Given this list of marker genes Mpi, Gck, Hk1, Man2c1, Man1c1, Gmppb, Man2b1, Pmm1, Pmm2, Man2a1, Man2a2 (mannosidase 2, alpha 2), Man2b2, here is a description of the gene set: Mouse Gene Set: GOBP_MANNOSE_METABOLIC_PROCESS species: Mus musculus The chemical reactions and pathways involving mannose, the aldohexose manno-hexose, the C-2 epimer of glucose. The D-(+)-form is widely distributed in mannans and hemicelluloses and is of major importance in the core oligosaccharide of N-linked oligosaccharides of glycoproteins.